Given this list of marker genes GBP7, RNF31, P2RY13, TLR4, AIF1 (NCBI Gene Id 9471), CASP1, CASP8 (NCBI Gene Id 841), DCK, SAMSN1, EPSTI1, IRF1, MNX1, GCH1, MPEG1, SELL, IL10, DHX58, STING1, FXYD5, MTHFR, AOAH, TIMP1, GZMB, RAB39A, TAPBPL, IFIT1, CCDC160 (NCBI Gene Id 347475), CXCL10 (C-X-C motif chemokine ligand 10), UBA7, PSME2, TLR6, STXBP1, GLA, APOBEC3B, TNFSF10, CXCL9, GIMAP4, DAXX, ARID5A, CXCL11, IL18BP, VWA5A, SAMHD1, FCGR1A, DENND2A, WARS1, OAS1, P4HA1, UBE2L6, GBP4, NMI, MS4A8, TRIM5, UBD, RIGI, TRAFD1, STAT1, BST2, EDEM1, RNF213, EIF2AK2, SERPINB9, BST1, XAF1, CALHM6, CCL2, CYBC1, DPYSL2, MX2, MARCHF5, HK3, RBM43, PARP3 (poly(ADP-ribose) polymerase family member 3), HERC6, TAPBP, ZNFX1, TOR3A, ZUP1, CD274, TAP1, KLRK1, CD200R1L, SLFNL1, IFI44L, C2 (complement C2), GNB4, SAMD9L, ZBP1, LCP2, CCR5, ADAR, BID, IFIT2, BATF2, CMPK2, RNF19B, SETDB2, CMTR1, OAS2, LY6E, STAT2, USP18, GIMAP7, IDNK, DTX3L, ECE2 (NCBI Gene Id 9718), ASGR2, TRIM25, CD72, NPC2, SASS6, IL2RG, IFI35, IFIH1, IFIT3, IRF8, RSAD2, PSMB10 (proteasome 20S subunit beta 10), MX1 (NCBI Gene Id 4599), PSMB8, SNX10, IRGM, RTP4, TMEM229B, TNFAIP2, NAMPT, IFI44 (interferon induced protein 44), HLA-G, HLA-E, ISG15, PNP, GBP6, STX7, OAS3, IL15, TOR1AIP2, IFITM3, EIF4E3, PML, NAAA, CASP4, RIPOR2, IKZF1, SLC28A2, SP110, PIK3AP1, HCK (NCBI Gene Id 3055), LYN, AIDA, CLDN14, FCGR3A, EPHA3, RNASE6, CD40, PROM1, SLFN5, CCL5, SLFN13, LACC1, RAP1B (NCBI Gene Id 5908), TUBB6, MLKL, CD180, IRF9, IFIT1B, LAIR1, ISG20, UBE2QL1, FANCA, PARP9, OASL, AREL1, TLR3, PARP14, GBP2, PSMB9, PTPRC, B4GALT5, SLAMF8, IRF7, BTK, THEMIS2, UBXN8, PRKX, PARP12, LIPG, TRIM21, TRIM34, ITPKA, GNE, MAP1S, TCIRG1 (T cell immune regulator 1, ATPase H+ transporting V0 subunit a3), GSDMD, INPP1 (NCBI Gene Id 3628), ETNK1, SIRPB1, SLAMF7, PSME1, TFEC, PARP11, here is a description of the gene set: We demonstrate that the G protein Gi3 is the cellular target of the adenosine A3 receptor (A3R). By using a cell permeable peptide comprising the C-terminal end of Gαi3 fused to an importation sequence (ALL1) as a selective inhibitor of Gi3 signaling, we show that by coupling to Gi3, the A3R stimulates multiple signaling pathways in human mast cells, leading to upregulation of cytokines, chemokines and growth factors.Following contact with activated T cell membranes, endogenous adenosine binds to and activates the A3R, resulting in Gi3-mediated signaling. Specifically, the majority of ERK1/2 signaling initiated by contact with activated T cell membranes, is mediated by Gi3, giving rise to ALL1-inhibitable cellular responses. These results unveil the physiological GPCR that couples to Gi3 and establish the important role played by this G-protein in inflammatory conditions that involve adenosine-activated mast cells. We used microarrays to detail the effect of ALL1 on gene expression of HMC-1 cells activated directly by the A3 receptor, or by contact with activated T cell membranes. Genes up-regulated in HMC-1 (mast leukemia) cells: incubated with the peptide ALL1 and then treated with Cl-IB-MECA versus stimulation by T cell membranes. Human Gene Set: GSE19888_ADENOSINE_A3R_INH_PRETREAT_AND_ACT_BY_A3R_VS_TCELL_MEMBRANES_ACT_MAST_CELL_UP from publication Baram D, Dekel O, Mekori YA, Sagi-Eisenberg R (PMID 20190146) studied in species Homo sapiens